Given this list of marker genes AQP4 (NCBI Gene Id 50660), EPHA7, RDX, SLC8A2, CCDC47, NRAS, DOC2A, RIOK3, TSPAN12, PPP1R12B, COL1A1, OSMR, HOXB6, ERG, COL14A1, TRERF1 (transcriptional regulating factor 1), CPD, ACER2, COL24A1, SMARCC1, MGAT4A, RGL2, PLPP6, CIMAP1B, GPCPD1, ARHGAP28, CLK2, ING5, DDX19B, LRRC17, IGDCC4, PYY2, ERLIN2, BACH1, LCOR, TNFSF12, RICTOR, GCNT4, EPC2, LTN1, PCYT1B, CDV3, SOCS4, RCC2, ABCB9, PDGFRA, LCORL, ACSL6, PCDH19, NKAPD1, IGF2BP1, CDYL, DCAF15, IGF2BP3, DENND6A, DCAF7, HOXA5, OPCML (opioid binding protein/cell adhesion molecule like), ZMYND11, LARP4, SOX12, HMGA2, SCRT2, SLC9A6, GAN, BIRC6, LIN28A, RBM26, CDKN1B, CPM, NAP1L1, SFSWAP, KATNBL1, ZCCHC3 (NCBI Gene Id 85364), CASK, OTX1 (orthodenticle homeobox 1), HAND1, SSR1, SYT9, CHRD, NR2C2 (NCBI Gene Id 7182), RANBP10, MIEF1 (NCBI Gene Id 54471), ADCY9, WDR37, RNF5, CNIH1, SLC31A1, C14orf28, NRK, HOXC8, RANBP2, HMGA1, NRARP, LIN28B, SNX16, BLOC1S6, PBX3 (NCBI Gene Id 5090), LRP4, CBFA2T3, DOCK3, MECP2 (methyl-CpG binding protein 2), GATA6 (NCBI Gene Id 2627), UHRF2, TSPAN18, CCM2L, FNIP1, CCDC93, ZNF655, ZNF385B, SOX11, GGA3, PPP1R15B, NME4, SCHIP1 (schwannomin interacting protein 1), LRP1B, COL3A1 (collagen type III alpha 1 chain), PPP6R2, MAP4K3, EPS15, HOXA7, ACVR2A, ZDHHC21, ELF4 (NCBI Gene Id 2000), YOD1 (YOD1 deubiquitinase), HOXA1, PPP1R16B, VSNL1, DDX19A, SDCBP, COL1A2, CALM3, SPINDOC, HOXB7, SMCR8, RSPO2, USP15, PAQR3, DNAAF3, GAS7, CCNJ, DICER1, PARP6, MANEAL, EXOC3L1, here is a description of the gene set: studied in species Homo sapiens Human Gene Set: ACTACCT_MIR196A_MIR196B Genes having at least one occurence of the motif ACTACCT in their 3' untranslated region. The motif represents putative target (that is, seed match) of human mature miRNAs hsa-miR-196a and hsa-miR-196b (v7.1 miRBase).